The following is a description of a gene set: Human Gene Set: GOBP_REGULATION_OF_CELLULAR_RESPONSE_TO_INSULIN_STIMULUS Any process that modulates the frequency, rate or extent of cellular response to insulin stimulus. studied in species Homo sapiens, and this is the list of marker genes: ECHDC3, PTPN11, IL1B, GSK3A, GRB7 (NCBI Gene Id 2886), BLVRB, RELA, GKAP1, PAK1, MIR195 (microRNA 195), OSBPL8, TRIM72, ZNF592, ZBTB7B, FBXW8, PTPRJ, SNX5, TRIB3, MAPKAP1 (MAPK associated protein 1), RPS6KB1, MIR15B, BGLAP, AHSG, SOCS1, SLC27A4, PTPRE, PRKCZ, KANK1, PRKCD, INS, MYO1C, PIP4K2B, PIP4K2C, SOCS3, NCL, NCOA2 (NCBI Gene Id 10499), PID1 (phosphotyrosine interaction domain containing 1), ERFE, MIR107, TNS2, MSTN, NR1H4, MTOR, IRS1, SORBS1, GPLD1, SIRT1, PTPN1, PRKCB, RBX1, MIR103A1, GRB10, SORL1, PIP4K2A, ATP2B1, TSC2, PRKCQ, RPS6KB2, PTPN2, C1QTNF12, NCOA1, NCOA5, KBTBD2, CTSD, LEP, LONP1, GPR21, ADIPOR1, APPL2, MIR1271, INPP5K, CUL7, IGF2, GRB14, PPARG, PRKAA1, NUCKS1, CUL3, ENPP1, SERPINA12, USO1, NCK1